The following is a description of a gene set: Human Gene Set: REACTOME_MEIOTIC_SYNAPSIS Meiotic synapsis species: Homo sapiens, and this is the list of marker genes: REC8, H2AC14, SMC3, SYCE3, H2BC3, SMC1B, H2BC26, SUN1, H2AC4, H2BC5, H2BC12L, H2AC18, SYCP3, H2AC8, H2BC12 (NCBI Gene Id 85236), H4C6, H2BC7, H2BC1, H2AZ2, BRCA1, H4C9, H2BC9, FKBP6, SYNE1, SYCE2, H2BC10, H2AJ, H2BC14, H4C14, HSPA2, H3-4, H2AB1, UBE2I, RAD21, H2AC20, TERF1, SYCE1, H4C2, H2BC8, H2BC15, SYCP2 (NCBI Gene Id 10388), H2BC13, DIDO1, H2BC17, H2BC4, TEX12, STAG2, H2AC19, H4C5, H4C13, TERF2IP, SUN2, H4C1, H4C15, POT1, STAG3, ATR, H2BC11, ACD, H4C8, STAG1, LMNA, H4C12, H2AX, H4C11, H4C16, H4C3, SMC1A, SYNE2 (spectrin repeat containing nuclear envelope protein 2), TINF2, H2BC6, H2AC6, H4C4, TERF2, H2AC7, LMNB1, SYCP1, H2BC21